The following is a description of a gene set: The change in morphology and behavior of a natural killer cell in response to a cytokine, chemokine, cellular ligand, or soluble factor. species: Homo sapiens Human Gene Set: GOBP_NATURAL_KILLER_CELL_ACTIVATION, and this is the list of marker genes: PRDM1, KIR3DS1, JAK2, TUSC2, CD2, SLAMF1, SP3, IFNE, IL12B, IFNB1, MICA, GAS6, EMP2, IFNK, KAT7, KLRK1, UNC13D, DCAF15, ULBP1, TOX, STAT5B, RPL13A (NCBI Gene Id 94020), ZBTB1, TYRO3, PTPRC, RABL3 (NCBI Gene Id 285282), CD160, NCR3, NKG7, AXL, IFNA4, IL2, PGLYRP2, FLT3LG, SNX27, IL18R1, IFNA14, BLOC1S6, VAMP7, IFNA5, KLRD1, NFIL3, CLNK, BLOC1S3, LAMP1, AP1G1, PGLYRP1, FYN, PIK3CD, IL21R, KLRC1, VAMP2, IL21, FCGR3A, IFNA8, IL12A, ULBP2, VAV1, IFNA17, KLRC2, TYROBP, PIBF1, CORO1A, SLAMF7, PRDX1, IFNA10, KLRC4-KLRK1, IFNA16, NCR1, RASGRP1, PTPN22, HLA-F, KLRC3, IL15, IL18, TICAM1, KLRF2, PGLYRP3, STAT5A, ZNF683 (zinc finger protein 683), CLEC12A, ULBP3, IFNA7, PBX1, HLA-E, IL23A, TYK2, IFNA21 (NCBI Gene Id 3452), CASP8, IFNA1, MIR130A, ID2, ELF4 (NCBI Gene Id 2000), LEP, RAB27A, IFNA2, FGR, RHBDD3, BAG6, CD48, IL15RA, HAVCR2, CD244 (CD244 molecule), IL23R, SH2D1A (SH2 domain containing 1A), MERTK (NCBI Gene Id 10461), IFNA6, IFNW1